Given this list of marker genes Gm25309, Sorbs2, Snx25, Gm20586, Rwdd4a, Tlr3, Gm15634, Stox2, Gm45607, Fam149a, Gm23666, Dctd, Tenm3, Gm17911, Gm31786, Cdkn2aip, Vegfc, Casp3, Gm22780, A230085B16Rik, Gm6458, Gm31172, Spcs3, 1700061N14Rik, Gm10313, Gpm6a, Cfap97, Spata4, Gm9892, Gm18320, Trappc11, Primpol, C130073E24Rik, Gm8575, Klkb1, Gm25830, Gm32975, Gm30931, Ufsp2, Ccdc110 (coiled-coil domain containing 110), Mtnr1a, Asb5, Gm19744, Gm8734, Pdlim3, Cldn22, 1190028D05Rik (RIKEN cDNA 1190028D05 gene), Aga, Cyp4v3, Gm24929, Gm30504, Gm24669 (NCBI Gene Id 115487021), 4930555F03Rik, Wwc2, Cfap96, Gm6329, Gm2366, Helt, Neil3 (NCBI Gene Id 97471), Gm39168, Wdr17 (WD repeat domain 17), Slc25a4, Lrp2bp, Gm22841, Sorbs2os, Gm2607, Gm32842, 1700011L03Rik, Ing2, Gm9685, Cenpu, Gm23986, AY512931, F11, Gm9908, Irf2, Ankrd37, Gm8623, Acsl1, Actg-ps1, E330018M18Rik, Gm2516, Gm32052 (predicted gene, 32052), Gm19921, Fat1, 4930579M01Rik, Gm8679, 9330121K16Rik, Cldn24, Gm16351, Gm6463, Enpp6, Gm25813, 5330439A09Rik, Gm45575, Gm22857, Gm16675, AA386476, here is a description of the gene set: Mouse Gene Set: chr8B1 species: Mus musculus